The following is a description of a gene set: Human Gene Set: SA_REG_CASCADE_OF_CYCLIN_EXPR Expression of cyclins regulates progression through the cell cycle by activating cyclin-dependent kinases. species: Homo sapiens, and this is the list of marker genes: CCNA1, E2F1, E2F2, CCNE2, CCNE1, CDKN2A, PRB1, CDKN1B, E2F4, CDK4, CCNA2, CCND1, CDK2